Given this list of marker genes HIF1A, FCGR3A, SNORD22, ADSS2, BTK, ALDOA, CAPNS1, ATG4B, BCL7B, LILRB3, ASH2L, WASF2, ATF1, STAT3, IDS, ATG13, LMO4, SULT1A2, PRR5, CD99L2, RBP2, ATP6V0B, TOB2, SLC35E1, MTMR3 (NCBI Gene Id 8897), TIMM23, NDRG3, STYXL1, TXNL1, CDYL, FCGR3B, NDUFS2, TCP1 (NCBI Gene Id 6950), TUBA1A, APLP2, TSPAN14, RTN3, RNF135 (ring finger protein 135), BRD7, GRIPAP1, TFEB, TRIM27 (tripartite motif containing 27), CSF2RA, EGLN2, FCGR2B, SMAP1, DIP2A, MGAM, SLC7A7, MARCO (macrophage receptor with collagenous structure), CALCOCO1, PRCP, RAD51, ITGB1BP1, TRGV5, CCT6A, R3HDM1, EWSR1, ME2, GBA2, WDR1, HERPUD2, GRN, POTEF, FBXO44, LAPTM5 (NCBI Gene Id 7805), FRA10AC1, CATSPER2, COMT, SULF2, CARS1, AGO3, NCF4 (neutrophil cytosolic factor 4, NCBI Gene Id 4689), NPLOC4, FBXO38, CNPY3, LMAN2, ATP6V0D1, CCS, SUOX, CARS2, PPP1CA, SPG21, DMC1, HSPA4, IL10RB (NCBI Gene Id 3588), MFF, H3C13, CSNK1D, MARS1, USP49, USP4, DNTTIP1, MIGA1, PSMC4, HTRA2, CYP51A1, STAB1 (NCBI Gene Id 23166), CTDP1, TCHP, PSPC1, ARHGAP30, LINC01720, CFP, MAPK14, PATE2, PRXL2A, PKM, PRKD2, KIR2DL3, HAL, TMEM69, CTNNA1, PRAM1, LSM6, VKORC1, RERE, SCN11A, SLC9A8, C2orf68, CDC123, TP53INP2, AAMDC, PABPC3, SLBP, H3-5 (NCBI Gene Id 440093), PTPRA, PBXIP1, SERPINA1, SLC2A14, HNRNPK, ANXA2P1, NCOA1, TRO, PSMB8 (NCBI Gene Id 5696), MACO1, KRT23, FAR2, HNRNPCL3, LINC01018, RAE1, SYAP1, PPP1R12B, SYK, SNRNP35 (NCBI Gene Id 11066), TADA2A, BIN2, MACROH2A1, RNF180, EIF4G2, SETD3, FTH1, CD14, NBPF3, PPFIBP2, ASTN2-AS1, GNB2, DHX9, RABL6, GNAI2, IQSEC1, PRKDC, LLPH, ARNT, RTN4, AGAP6, BICRAL, RASSF5, GAPDH, UGGT1, BIN3, HNRNPA3, TERF2IP, NFYA, FAM238B, NUP62, LRTOMT, TNFAIP2, CAST, GTF2H1, POTEM, PRKCB, CD163, AP1B1, CORO1C, SPPL3 (signal peptide peptidase like 3), PMS2CL, HNRNPAB, SEC24D, VPS18, STX5, NUDT22, SEC23B, HLA-F, REL, CXCL16, CBX4, POLR2J3, ADAT1, SP110, SRPK2, PATL2, WDR82, DDX19A, PXN, ARRDC3, BRD10, SLC25A20, PSEN1, DTWD2 (DTW domain containing 2), SF1, TDRD1, ARPIN, RELA, CEP19, PGAM4, TTF1, SULT1A3, HADHB, PID1, TECPR2, PI4KAP1, TOR3A, SPG11, DCAF6, SEC13, MED8, WDR5, RBM4 (RNA binding motif protein 4), TTC9C, PRKCZ, U2AF1, MTMR4, LSP1, ARHGAP9, MILR1, PNPT1, ITPK1 (NCBI Gene Id 3705), KLF6, DTX2, GALNT10, NUBPL, BCLAF1 (NCBI Gene Id 9774), PHAX, CSGALNACT2, TM9SF1, NDUFA10, LMOD3, TNFRSF8, TUBA1C, H6PD, IL16, DUSP22, UIMC1, CDK5RAP3, ACP2, UBE4B, SORD, ZC3H7A, SPTLC1, USP48, BRD1, RMC1, ECHDC3, PIGS, GLE1, GALNT3, PLAUR, VAC14, NFYC, RPP38, MCMDC2, IFFO1, ORAI3, WNK1, PGAM1, RNF213, CCT7, HSF1, CALHM2, ORAI2, SLC25A51, ZNF557, FKTN, CD63, ZMYND15, GIT2, HSPA1A, CPVL (NCBI Gene Id 83484), MINDY2 (MINDY lysine 48 deubiquitinase 2), MGAM2, RGL2, ABCG1, FAM86KP, ERGIC1, ALDH2, ANXA11, APOBR, NLRP12, LRRC25, RANGRF, KLHL18, NDUFB9, MPLKIP (NCBI Gene Id 136647), KEAP1, STK32B, BLTP2, RDH10, CAPG, PHC3, TLR1, MAZ, QKI, OTX1, LRRK1, NLRP1, OS9, RPN2, KIAA0319L, AMY1B, ABAT, FAM193A, ILK, PHRF1, CTBP1, SQOR, HPSE, KDELR1, RNF130, DDX19B, COL4A2, VPS41, FYN, BST2, EPB41L3, ANKZF1, IL18, KLF4, CDKN1C, AKAP13, CPPED1, CAPRIN1, here is a description of the gene set: Genes down-regulated in blood cohort 1 (re-vaccinated in 6-9 months) vs cohort 2 (re-vaccinated in 12-13 months) in adults (65+) after exposure to 2012-2013 seasonal trivalent inactivated influenza vaccine (TIV), time point N/A. Comment: Cohort 1 (re-vaccinated in 6-9 months) vs Cohort 2 (re-vaccinated in 12-13 months) Human Gene Set: KANNAN_BLOOD_2012_2013_TIV_AGE_65PLS_REVACCINATED_IN_6_9_MO_VS_REVACCINATED_IN_12_13_MOS_DN We tested antibody responses to the trivalent inactivated influenza vaccine (TIV) in 34 aged individuals ( > 65 yrs) during the 2012/13 vaccination seasons. Nearly all had been vaccinated the previous year although the time interval between the two vaccine doses differed. One subgroup was re-vaccinated in 2012/13 within 6-9 months of their 2011/12 vaccination, the other received the two doses of vaccine in the typical ~12 month interval. Unexpectedly the sub-cohort with early revaccination exhibited significantly increased response rates and antibody titers to TIV compared to their normally re-vaccinated aged counter parts. Microarray analyses of gene expression in whole blood RNA taken at the day of the 2012/13 re-vaccination revealed statistically significant differences in expression of genes between the individuals with early re-vaccination compared to subjects vaccinated in a normal 12 month interval. These observations suggest that TIV has long-lasting effects on the immune system affecting B cell responses as well as the transcriptome of peripheral blood mononuclear cells and this residual effect may augment vaccination response in patients where the effect of the previous vaccination has not yet diminished. species: Homo sapiens from publication Kannan S, Kossenkov A, Kurupati RK, Xiang JZ, Doyle SA, Schmader KE, Schowe L, Ertl HC (PMID 26637961)